The following is a description of a gene set: Genes down-regulated in resting T reg versus T conv cells. species: Homo sapiens from publication Collison LW, Chaturvedi V, Henderson AL, Giacomin PR, Guy C, Bankoti J, Finkelstein D, Forbes K, Workman CJ, Brown SA, Rehg JE, Jones ML, Ni HT, Artis D, Turk MJ, Vignali DA (PMID 20953201) Human Gene Set: GSE24210_RESTING_TREG_VS_TCONV_DN Regulatory T cells (Tregs) play a critical role in the maintenance of immunological self-tolerance. Naïve human or murine T cell treatment with the inhibitory cytokine IL35 induces a regulatory population, termed iTR35, that mediates suppression via IL35, but not IL10 or TGFβ, neither express nor require Foxp3, are strongly suppressive in five in vivo models, and exhibit in vivo stability. Treg-mediated suppression induces iTR35 generation in an IL35- and IL10-dependent manner in vitro, and in inflammatory conditions in vivo in Trichuris-infected intestines and within the tumor microenvironment, where they appear to contribute to the regulatory milieu. iTR35 may constitute a key mediator of infectious tolerance and may contribute to Treg-mediated tumor progression, and ex vivo-generated iTR35 may possess therapeutic utility., and this is the list of marker genes: SOX13 (NCBI Gene Id 9580), ZRANB2, CCT2, CASP4, PUS7, GNL3L, WASHC5, CA13, CHCHD1, EIF3B, REM2, NDUFB2 (NADH:ubiquinone oxidoreductase subunit B2), GRPEL1, CCT6A, AKR1B1, PNPO, RBM19, ACO1 (NCBI Gene Id 48), HINT1, GLCE (NCBI Gene Id 90998), TMEM147, CPTP, DDX18, ELAC2, DPY30, PUS7L, OLA1, API5, FASTKD5, LPCAT3, MED17, MAK16, PBDC1, ADAMTS5, CCL4, MRPL13, BYSL, EIF2B3, ZNF768, PSMA6, SF3A1, ZNF689, CCR9, SNHG3, SMPD4, CDC34, HMBS, PIGY, PKM, PVT1, SQLE, MESD, ARL8B, YES1, USP28, RNASEH2B, POLR2F, GTF2I, BZW2, COPS8, PSMF1, TMEM51, CNDP2, PCYT2, CLUH, AXL, SEPTIN11, MSMO1, FAM162A, TCEA2, SHQ1, MRPL46, PUM3, NSMF, IL1R1, TXNL1, POLR1D, JAGN1, SLC7A5 (solute carrier family 7 member 5), GSTO1, RBBP7, TPRKB, SNRPC (small nuclear ribonucleoprotein polypeptide C), PRPF31, PPP2CA, NDUFAF2, CKAP5, MYO1D, GPN1, IL10, NAP1L4, METTL13, NAA20, GEMIN5, YBX1, CRH, NUBP1, NAT10, TBC1D7, JRK, NDUFC2, DGKH, RCC1, HMGCS1, NUDT2, ZDHHC3, TRAPPC3, HIVEP3, POLR1G, RFTN1, CWC27, CCNH, AHSA1, NAA10, BSPRY, MRPS31, POLR3B, COMTD1, CRISP3, DPY19L3, YIF1B, BEX1, ESD, ZMYND19, MTHFD1, LRP8 (NCBI Gene Id 7804), SLC35F2, NDUFA7, ADI1, RBMXL1, PSMG1, RUVBL1, SRM, MBD3, FAM98A, DDX31, GFM1, MCC, CYBA (cytochrome b-245 alpha chain), AKT2, PSMA4, HSPE1, ACTR10 (actin related protein 10), SLC25A1 (solute carrier family 25 member 1), EIF2S2, TMEM41A, NDUFC1, GLRX2, AGK, EIF4A3, IFRD2, PTBP1 (NCBI Gene Id 63477), EIF3J, FOSL1, TLE4, GSR, MRPL22, MED9, CNIH4, PDCD5, RUVBL2, HAT1, ABCC4, RRP9, UNG, YAE1, PWP1 (PWP1 homolog, endonuclein), PHF23, NCBP1, RPL7L1, SLC5A6, ARV1 (ARV1 homolog, fatty acid homeostasis modulator), ATP5MC2, LSM6, QTRT2, CLPP, SSBP1, SLC35F5, XPO7, PRDX1, OAF, CCNQ, PHB2, NQO1, NHP2, NELFE, ATP5MF, GPAT4, SNRPA1, NEFH, TMEM256, NOP2, GCSH, FBXO6, RSL1D1, TSEN2, RARS2, TBCB, ABI2, PTTG1